Given this list of marker genes BABAM1, CHEK1, TIMELESS, H2BC21, H4C5, UBB, EME2, H2BC4, RAD1, H4C3, RFC5, RAD9A, POLD1, WRN, RAD51, RPA1, RAD52, BRCA2 (NCBI Gene Id 82716), H2BC11, RNF4 (NCBI Gene Id 6047, ring finger protein 4), POLQ, UBE2V2, POLH, ATM, UBC (NCBI Gene Id 7316), ERCC4, FEN1, RBBP8, H2BC9, SUMO2, ATR, H2BC15, RFC2, DNA2, POLD4, H4C14, KAT5, PARP1, ABRAXAS1, ERCC1, PCNA, H2BC12L, HERC2, H2BC7, POLE2, H2BC12, CDK2, HUS1, H4C16, SLX1A, TP53BP1, H2BC13, SPIDR, SLX4, SLX1B, GEN1, RAD9B, NSD2, PALB2, NBN, H4C9, CCNA1, RAD51D, RAD17, MUS81, POLD2, H3-4, H2BC8, POLE4, RFC1, ATRIP, XRCC3, RHNO1, H2BC17, H4C8, H2AX, H4C2 (NCBI Gene Id 8366), POLE, FIRRM, BLM, TOP3A, CCNA2, BRIP1 (NCBI Gene Id 83991), H2BC3, UBA52, PPP4C, H4C1, UBE2I, EME1, H4C13, H4C12, RMI2, BRCA1, H2BC26, TOPBP1 (DNA topoisomerase II binding protein 1), UIMC1, H4C6, XRCC2, SIRT6, RFC4, SEM1, RAD50, RNF8, TIPIN, PPP4R2, FIGNL1, BARD1, BRCC3, POLK, RNF168, RFC3, H2BC14, POLD3, UBE2N, H2BC10, RPA3, RPS27A, MRE11, BABAM2 (BRISC and BRCA1 A complex member 2), MDC1 (mediator of DNA damage checkpoint 1), POLE3, H4C15, XRCC1, H4C4, RAD51C, H2BC1, H2BC5, H4C11, ABL1, RPA2, PIAS4, RMI1, CLSPN (NCBI Gene Id 63967), RAD51B, RTEL1, LIG3, H2BC6, PARP2, EXO1, RAD51AP1, here is a description of the gene set: Human Gene Set: REACTOME_HOMOLOGY_DIRECTED_REPAIR studied in species Homo sapiens Homology Directed Repair